Given this list of marker genes ELL, INHBA, DDX21, MTOR, MYBBP1A, BAZ1B, ERCC6, DEK, ZNF143, AR (androgen receptor), RPTOR, ICE2, ICE1, SMARCA5, CHD8, SF3B1, MYO1C, ZC3H8, here is a description of the gene set: species: Homo sapiens Any process that activates or increases the frequency, rate or extent of transcription mediated by RNA polymerase III. Human Gene Set: GOBP_POSITIVE_REGULATION_OF_TRANSCRIPTION_BY_RNA_POLYMERASE_III